The following is a description of a gene set: studied in species Homo sapiens Human Gene Set: GOBP_TRNA_MODIFICATION The covalent alteration of one or more nucleotides within a tRNA molecule to produce a tRNA molecule with a sequence that differs from that coded genetically., and this is the list of marker genes: DTWD2, PUSL1, PUS7, GTPBP3, QTRT1 (queuine tRNA-ribosyltransferase catalytic subunit 1), TRMT13, TRDMT1, TRMT12, DPH3, QNG1, TRMU, ELP1, TYW1, PUS10, THG1L (tRNA-histidine guanylyltransferase 1 like), MTO1, SEPSECS, MTFMT, TRMT10C, KTI12, ELP4, OSGEPL1, SARS1, FTSJ1, TYW1B, YRDC, METTL8, QTRT2, TARBP1, TRMT1, DALRD3, TRMT61A, DUS1L, THUMPD3, WDR4, DUS4L, TRMT6, ANKRD16, METTL2B, TPRKB, ALKBH1, ELP5, HSD17B10 (hydroxysteroid 17-beta dehydrogenase 10), AARS1, TRMT5, TRMT44, PUS3, METTL6, DUS2, URM1, METTL1, ELP6, TRMO, ELP3, DUS3L, ELP2, NSUN2, TRMT10A, DTWD1 (DTW domain containing 1), MOCS3, TRMT61B, TRMT9B, GON7, NSUN3, CTU2, RPUSD4, TRUB1, OSGEP (NCBI Gene Id 55644), THUMPD1 (THUMP domain containing 1), TYW5, THUMPD2, ALKBH8, LCMT2, CDK5RAP1, METTL2A, B3GNTL1, WDR6, NAT10, CTU1, NSUN6, GTDC1, PUS1, THADA, BCDIN3D, TRMT112, TRMT1L, AKT1, ADAT2, TRMT10B, TRIT1 (tRNA isopentenyltransferase 1), CDKAL1, TYW3, SSB